Given this list of marker genes PLCH1, HMBS, PIGN, POMT2, OPHN1, PACS1, here is a description of the gene set: Congenital absence of a part of the vermis of cerebellum. Partial absence of cerebellar vermis Human Gene Set: HP_PARTIAL_ABSENCE_OF_CEREBELLAR_VERMIS species: Homo sapiens